Given this list of marker genes Camk2d, Mef2d, Suv39h1, Rnpc3, Mxd4 (NCBI Gene Id 69247), Mgrn1, Dnajb6, Sgms1, Hspa8, Kntc1, Pdk4, Arsb, Cela1, Poc1b, Ap3d1, Uqcrfs1, H4c1, Mynn, Ahnak, Azi2, Fam83f, Sparcl1, Azin2, Tspo, Trim41, Ccm2, Slc27a1, Rad51d, Gys1, Tle3, Eri2, Pi4k2a, Mrps5, Polr1d, Chst8, Fgd6, Dennd2d, Hes7, Rb1, Zfp408, Unc45a, Krt19, Emc4, Klk10, Arhgef2, Septin9, Angptl1, Picalm, Pkmyt1, Nagk, Bag2, Sin3a (transcriptional regulator, SIN3A (yeast)), Hsd17b10, Kank1, Kri1, Sap30, Disp2, 3300002I08Rik, Hddc3, Dysf, Ihh, Gstm7 (NCBI Gene Id 99761), Zfp943, Per1, Ikzf2, Tssk1, Decr1, Shisa5, Foxp1, Arl6, Rdh16, Prkag2, Bcap31, Zbtb7b, Ndufb10 (NCBI Gene Id 68342), Acsm5, Lgals9, Abcd1 (ATP-binding cassette, sub-family D member 1), Prkar2b, Clpx, Zfp91, Prune1 (prune exopolyphosphatase), Dusp22, Gnas, Akirin2, Rnf125, Tgfb1i1, Uaca, Phb2, Fancc, Met, Mettl17, Pemt, Hsd17b4, Gstm3, Irs3, Arhgef10, Fzd8, Acaca, Ak3, Wwtr1, Numa1, Ncor1, Jade2, Ebf1, Tmem69, Ndufa2, Odad4, Mdfic, Commd5, Tmem109, Prkar1a, Eml4, Cend1, Tmem43, Plin2, Clpp, Apon, Fbxl6, Dhrs7, Ttc7, Ube2w, Megf9, Pigm, Lrrc8a, Numb, Ptges, Emg1, Gdf9 (growth differentiation factor 9), Cd1d1, Pnpla7, Psmf1, Isoc1, Pias4, Klf10, Casp9, Spag9, St3gal4, Slc44a3, Invs, Tmem201, Oas1f, Cdca7, N4bp2l1, Gemin4, Fkbp14, Plxna1, Med11, Atp5me, Hcar1, Adamts15, Calm1, Tmie, Rnf8, Plxdc1, Loxl2 (lysyl oxidase-like 2), Hoxa9, Mtor, Brd2, Dixdc1, Ndufab1 (NCBI Gene Id 72270), Vcp, Mri1, Palm, Zfp672, Dnajc5, Hadha, Tmem176a, Dicer1, Atosb, Cpe, Hprt1, Timeless, Gsdme, Faf1, Purb, Vegfa, Spef1 (NCBI Gene Id 70997), Ik, Wnk4 (NCBI Gene Id 69847), Nav1, Ccdc77, Tmem98, Mov10, Rwdd3, Arhgdib, Il6ra, Itih4, Uqcrq, Mtmr4, Spsb1, Cfap36, Arhgef7, Atp6v1a, Slc3a2, Zfp748, Rbm14, Tmem38b (NCBI Gene Id 72005), Brca1, 5730507C01Rik, Ttc19, Zfp661, Eif6, Gbp2b, Tnfaip3 (tumor necrosis factor, alpha-induced protein 3), Cdadc1, Mmp11, Phlda3, Nfe2l2, Cpsf7, Dctn2, Zfp444, Mib1, Dnaja2, Pebp1, Cbr1, Ppp4r3b, Rbm48, Ndufb2, Ankrd17, Ces1f, Epn3, Afmid, Itga1, Lpxn, Itga5, Mpdu1, Zhx3, Cep250, Plcg1, Tssk2, Arhgef40, Ubb, Adam9, Sptbn1, Cd164, Hadhb, Mast2, Babam2, Klra10, Scrt1, Csrnp2, Dck, Fbf1, G0s2, Trpd52l3, Lurap1l, Creld1, Glcci1, Ago1, Ibtk, Gbp6, Phf12 (NCBI Gene Id 76807), Trim69, C2cd3, Rorc, Osbpl9 (oxysterol binding protein-like 9), Klhl7, Rfxap, B3gat3, Ciapin1, Blcap, Ttc23, Tmem135, Iqcb1, Gnpat, Chad, Ccdc141, Ninj1, Zfp944, Thpo (thrombopoietin), Gramd1a, Irf4, Rprml, Tspan14, Zfp574, Thoc1, Aspn, Ctu1 (NCBI Gene Id 233189), Adrb3, Gstt2, Angpt1, Mrpl41, Rad51b, Krt14, Gbp7, Grtp1, Syap1, Trappc11, Actrt3, Sos1, Afap1l2, Bcorl1, Spsb2, Rock2, Dido1, Myc, Cdh13, Ikzf1, Krt15, Mab21l2, Ehmt1, Vmp1, Iqcc, Polk, Arpc5, Spata3, Coq9, Fbxw4, Rsrc2, Fads3, Zfp68, Eya1, Polr1h, Zrsr2, Ly6g6c, Acly, Ablim1, Wdr35, Epb41l1, Helb, Gmfb, Acsf2, Prr14, Zfp36l2, Jak3, Wdr82 (WD repeat domain containing 82), Itga7, Nudt21, Aip, Orc3, Mbd4, Cuedc1, Cradd, Supt3, Zfp991, Runx2, Ywhah, Chst5 (carbohydrate sulfotransferase 5), Rab11fip4os1, Rcl1 (RNA terminal phosphate cyclase-like 1), Ei24, Leng1, Yipf3, Oaf, Deptor, Dhx35, Lysmd3, Fnbp1l, Chrd, Rbl1, Ezh2, Nagpa, Caprin1, Abcf1 (NCBI Gene Id 28122), Klkb1, Chit1, Chchd4, Fbxw5, Alas1, Rbks, Numbl, Hcar2, Dhrs11, Grhpr, Cln5, Ubap1, Speg, Aptx, Erlin2, Ccl9, Lpcat3, Pafah1b1, Erp44, Fhl3, Traf4, Lrch3, Eif2ak4, Plk1, Akap1 (NCBI Gene Id 97733), St3gal6, Ptrh2, Lnx2, Hspd1 (heat shock protein 1 (chaperonin)), Rbak, Atp6v1d, Setd4, Ctps2, Znf41-ps, Ak1, Optn, Ubiad1, Grb2, Fkbp10, Fbxw11, Dlat, Als2cl, Pts, Cyb5d2, Tmigd1, Arhgap1 (Rho GTPase activating protein 1), Pus1, Stard7, Lgi4 (leucine-rich repeat LGI family, member 4), Ate1, Gnasas1, Aacs, Airn, Scaf4, Cilk1, Xpa, Mllt10, Igfbp7, Bhlhe41, Dyrk1a, Chd1, Lzic, Dgcr8, Bivm, Tmem126b, Slc5a3, Shprh, C1qtnf2, C1qtnf12, Zfp867, Gypc, Osbpl3, Anxa8, Chst1, Nr4a3, Safb2, Pccb, Cbx8, A430033K04Rik, Kif5c, Dcun1d4, Prpf38b, Rtel1, Glb1, Mapkapk5, Sdccag8, Ppme1, Prelid2, Hspe1, Mrps6, Cyld, Ing4, Tmbim6, Tfb1m, Faim, Wdr6, Trim25, Irx5, Setdb1, Cited2, Top2a, Ccni, Me1, Klb, Zfp7, Add3, Cers2, Spry4, Ak2, C130050O18Rik, Gna13, Gbp3, Ell, Mterf4, Ubap2, Vmn1r62, Hopx, Polr2g, Boc, Acp2, Rpa3, Bid, Mib2, Nelfcd, Mocs1, Eaf2, Thap3, Sema6d, Cenpb, Tm2d2, Sphk2, Sp3, Apobr, Irx3, Gnaq, Cxcl9, Plscr1, Elmo2, Zbtb21, Aldh1a7, Cdk14, Aldh2, Gstm6, Mtpap, Rbm39, Eif2s1, Pwwp3a, Dus3l, Zbtb3, F3, Gpr182, Gsg1, Hipk2, Chchd6, Gnaz, Pla2g12a, Zzef1, Lims1, Dlx5, Rabgap1l, Hexim2, Rars2, Palmd (palmdelphin), Gtf2i, Rimoc1, Rpia, Rasl11b, Osbpl2, Top1, Lpin1, Usp15, Hspa9, Zfp708, Lmln, Dcbld2, Serpinb9, Klra8, Gstm1, Zfp423, Eno1, Trabd, Trim23, Birc6, Lpin2 (lipin 2), Zbtb2, Rara, Fbxo9, Cth, Krt4, Arhgef6, Calml3, Igfbp1, Ero1a, Lix1, Hint3, Galnt4, Sik2, Galnt7, Dld, G6pc1, Arl6ip6, Il6st, Gstm2, Lgals3, Mb, Ppp1r37, Prpf40a, Meis2, Rmdn2, Sec63, Sde2, Eef1a2, Txnrd1, Paxx, Sgo2a, Stk11, Baat, Krt79, Insr, Fads1, Inpp5f, Coro1b, Acsl1, Cyb5r3, Pgam1, Hcls1, Dgcr2, Ift140, Mark2, Spin4, Bcas3, Arsa, Nhej1, Prkrip1, Dnajc16, Prkca, Rab11fip4, Acot13, Arhgef12, Abr, Fkbp7, Mkks, Esco2, Dut, Fbh1, Wwp2, Rmnd1, Itpka, Zbtb40 (NCBI Gene Id 230848), Actn4, Prkce, Zfp24 (zinc finger protein 24), Calr3, Pgm1, Tusc2, Chsy1, Tk1, Oxsm, Npr3, Wdr41, Prpf18, Aktip, Egr1, Tmem39a, Plin4, Frmd5, Atl2, Abhd2, Pcgf5, Rwdd4a, Ift122, Fosl2, Tob1, Usp14, Zfp758, Slc52a2, Nol6, Klra4, Krt13 (NCBI Gene Id 16663), Usp48, Acta1, Spon2, Arhgap18, Keap1, Ppp2r5d, Fsd2, Tmem176b, Aldh9a1, Ruvbl2, Kdm7a, Dctn4, Ift81, Crls1, Prps1, Cab39l, Ucp3, Lrrc28, Sox4, Atxn7l2, Map2k1, Sod1, Cpt2 (NCBI Gene Id 12896), St3gal3, Klra7, Wls, Bri3bp (Bri3 binding protein), Edf1, Gsk3b, here is a description of the gene set: Mouse Gene Set: WAKABAYASHI_ADIPOGENESIS_PPARG_BOUND_8D Control of cell differentiation occurs through transcriptional mechanisms and through epigenetic modification. Using a chromatin immunoprecipitation-on-chip approach, we performed a genome-wide search for target genes of peroxisome proliferator-activated receptor gamma (PPAR gamma) and its partner protein retinoid X receptor alpha during adipogenesis. We show that these two receptors target several genes that encode histone lysine methyltransferase SET domain proteins. The histone H4 Lys 20 (H4K20) monomethyltransferase PR-Set7/Setd8 gene is upregulated by PPAR gamma during adipogenesis, and the knockdown of PR-Set7/Setd8 suppressed adipogenesis. Intriguingly, monomethylated H4K20 (H4K20me1) levels are robustly increased toward the end of differentiation. PR-Set7/Setd8 positively regulates the expression of PPAR gamma and its targets through H4K20 monomethylation. Furthermore, the activation of PPAR gamma transcriptional activity leads to the induction of H4K20me1 modification of PPAR gamma and its targets and thereby promotes adipogenesis. We also show that PPAR gamma targets PPAR gamma2 and promotes its gene expression through H4K20 monomethylation. Our results connect transcriptional regulation and epigenetic chromatin modulation through H4K20 monomethylation during adipogenesis through a feedback loop. from publication Wakabayashi K, Okamura M, Tsutsumi S, Nishikawa NS, Tanaka T, Sakakibara I, Kitakami J, Ihara S, Hashimoto Y, Hamakubo T, Kodama T, Aburatani H, Sakai J (PMID 19414603) studied in species Mus musculus Genes with promoters bound by PPARG at 8 day time point of adipocyte differentiation of 3T3-L1 cells (preadipocyte).